The following is a description of a gene set: from publication Nakayama T, Hieshima K, Arao T, Jin Z, Nagakubo D, Shirakawa AK, Yamada Y, Fujii M, Oiso N, Kawada A, Nishio K, Yoshie O (PMID 18071306) Adult T-cell leukemia (ATL) is a mature CD4+ T-cell malignancy etiologically associated with human T-cell leukemia virus type 1 (HTLV-1). Primary ATL cells frequently express CCR4 at high levels. Since HTLV-1 Tax does not induce CCR4 expression, transcription factor(s) constitutively active in ATL may be responsible for its strong expression. We identified an activator protein-1 (AP-1) site in the CCR4 promoter as the major positive regulatory element in ATL cells. Among the AP-1 family members, Fra-2, JunB and JunD are highly expressed in fresh primary ATL cells. Consistently, the Fra-2/JunB and Fra-2/JunD heterodimers strongly activated the CCR4 promoter in Jurkat cells. Furthermore, Fra-2 small interfering RNA (siRNA) or JunD siRNA, but not JunB siRNA, effectively reduced CCR4 expression and cell growth in ATL cells. Conversely, Fra-2 or JunD overexpression promoted cell growth in Jurkat cells. We identified genes, including c-Myb, BCL-6 and MDM2, which were downregulated by Fra-2 siRNA in ATL cells. c-Myb, BCL-6 and MDM2 were also downregulated by JunD siRNA. As Fra-2, these proto-oncogenes were highly expressed in primary ATL cells but not in normal CD4+ T cells. Collectively, aberrantly expressed Fra-2 in association with JunD may play a major role in CCR4 expression and oncogenesis in ATL. Human Gene Set: NAKAYAMA_FRA2_TARGETS Genes down-regulated in ST1 cells (adult T-cell leukemia, ATL) after knockdown of FRA2 by RNAi. species: Homo sapiens, and this is the list of marker genes: ING3, BCL6, GPR18, NR1D2, CLEC2B, MKRN1, MDM2, YTHDF3, SGK1, LGMN, RBM33, DUSP10, FBXO32, TFPI, MT1H, RGS2, KLHDC7B, F2R, MYB, HSPA1B, ZFAND5, SOX4, DBP, SQSTM1 (sequestosome 1), LGR4, CHN1, SDCBPP2 (NCBI Gene Id 100129960), MT2A, SPSB3, GPRIN3, SLC30A1, CTTN, SLC20A1, DUSP4, CREBRF, TAGAP, KLHL24, CDK2AP1, CKAP2, EIF4G3, DNAJB1, MT1F, ZMAT3, WIPF1